Given this list of marker genes GRIK2, GNG7, DRD4, GRPR, ADRB1, LYPD1, UCN, NEUROD2, DPP4, EIF4E, NPAS2, KCTD16, ANKFN1, ADRA2A, DEAF1, VDAC3, PENK, SLITRK4, ASIC1, BRINP1, GRP, MORC1, CRHR1, FBXL20, RAG1, NR2E1, HTR2C, EIF4G1, APOE, MAPK8IP2, DBH, MECP2, EPHB2, GABRA5, COMT, MEF2C, CRH, USP46, PRKAR1B, PDE8B (phosphodiesterase 8B), ALS2, VDAC1, ATP1A2, GRM7, NPY2R, BCL2, DRD1, MDK, SLC1A1, ASIC4, HTR1A, LARGE1, EXT1, RPS6KB1, here is a description of the gene set: Human Gene Set: GOBP_FEAR_RESPONSE The response of an organism to a perceived external threat. species: Homo sapiens